Given this list of marker genes Nefl, Gata6, Eif3a, Aopep, Fam168a, Zfp322a, Zfp827, Galnt7, Gtf3c5, Armh3, Ccdc86, Nrdc, Klhl15, Larp4b, Dnmt3a, Lrrtm4, Met, Rffl, Slc17a8, Fiz1, Ccnc, Rad1, Zbtb21, Musk, Neto1, Ebf1, Mylk2, Pbx1, Camkk2, Ptdss1 (phosphatidylserine synthase 1), Zkscan1, Mb21d2, Tafa2, here is a description of the gene set: Genes predicted to be targets of miRBase v22 microRNA mmu_miR_6931_3p in miRDB v6.0 with MirTarget v4 prediction scores > 80 (high confidence targets). studied in species Mus musculus from publication Chen Y, Wang X (PMID 31504780) Mouse Gene Set: MIR_6931_3P